The following is a description of a gene set: species: Homo sapiens Enables the transfer of a tripeptide, a compound containing three amino acids linked together by peptide bonds, from one side of a membrane to the other. Human Gene Set: GOMF_TRIPEPTIDE_TRANSMEMBRANE_TRANSPORTER_ACTIVITY, and this is the list of marker genes: ABCC1, ABCC5, ABCC4, SLC13A3, SLC25A39, SLC15A2, SLC15A1, GJA1, SLC25A40